The following is a description of a gene set: Human Gene Set: GOBP_GLYCOSYL_COMPOUND_METABOLIC_PROCESS The chemical reactions and pathways involving glycosyl compound. species: Homo sapiens, and this is the list of marker genes: MAPDA, XDH, TYW5, DGUOK, DCTD, NT5C2, ADA, GBA1, AKR1C1, AICDA, ENPP4, SLC34A1, AKR1C4, UPP2, NME4, UPB1, ACP3, ERH, UPP1 (uridine phosphorylase 1), AKR7A2, DPYD, UCKL1, SULT1C4, NT5C3A, AKR1A1, PNP, TYW3, NT5C1B, NUDT1, TRMT12, PGM2, CDA, HPRT1, MACROD2, AKR1B10, BLOC1S6, CDADC1, APOBEC3G, DHFR2, AKR1C3, TYW1, TYW1B, DERA, ADK, TYMP, MACROD1, NME5, FUCA2, ICMT, GBA2, OARD1, CBR4, NT5C1A, NAGA, GDA, GBA3, ADA2, MTAP, DNPH1, PRTFDC1, AKR1C2, PTGDR, GNMT, TK1, QNG1, TK2, DTYMK, APRT, GLA, LCMT2, AKR1B1, APOBEC3C, NT5E, FUCA1